Given this list of marker genes Aimp2, Gata6, Fgf10, Nfib (nuclear factor I/B), Nkx2-1, Fndc3b (NCBI Gene Id 99920), Rbbp9, Igf1, here is a description of the gene set: The process in which a relatively unspecialized cell acquires specialized features of a type II pneumocyte. A type II pneumocyte is a surfactant secreting cell that contains abundant cytoplasm containing numerous lipid-rich multilamellar bodies. species: Mus musculus Mouse Gene Set: GOBP_TYPE_II_PNEUMOCYTE_DIFFERENTIATION